The following is a description of a gene set: from publication Gavish A, Tyler M, Greenwald AC, Hoefflin R, Simkin D, Tschernichovsky R, Galili Darnell N, Somech E, Barbolin C, Antman T, Kovarsky D, Barrett T, Gonzalez Castro LN, Halder D, Chanoch-Myers R, Laffy J, Mints M, Wider A, Tal R, Spitzer A, Hara T, Raitses-Gurevich M, Stossel C, Golan T, Tirosh A, Suvà ML, Puram SV, Tirosh I (PMID 37258682) Genes upregulated in subsets of cells of a given type within various tumors studied in species Homo sapiens Human Gene Set: GAVISH_3CA_METAPROGRAM_ENDOTHELIAL_HEV_2 In this study, an extensive analysis was conducted to define meta-programs (MPs) capturing intra-tumor heterogeneity across a spectrum of tumor types. The approach utilized non-negative matrix factorization (NMF) to analyze each cell type separately within individual tumor samples. This involved the analysis of malignant cells, macrophages, fibroblasts, endothelial cells, epithelial cells, T-cells, and B-cells. NMF was executed with varying parameter values (K=4, 5, 6, 7, 8, 9), thereby generating 39 programs for each cell type per sample. Each NMF program was summarized by the top genes based on NMF coefficients.\nRobust MPs were then delineated for each cell type using a set of stringent criteria, including recurrence within the same tumor, similarity to programs in other tumors, and non-redundancy within a tumor. Subsequently, these robust NMF programs were clustered (per cell type) based on Jaccard similarity, leading to the identification of MPs associated with each cell type.\nTo enhance the quality of the MPs, a refinement steps were undertaken, involving the removal of MPs suspected of reflecting low-quality data (with an overrepresentation of ribosomal proteins or mitochondrial-encoded genes), single-study inclusion, or similarity to miss-annotated cell types., and this is the list of marker genes: SELP, NOS3, ADAMTS1, THBD, CALCRL, ADAM15, ITGA6, ADAMTS6, PTGDS, TSHZ2, TGM2, FBLN2, ENTPD1, PLEC, VCAM1, PCDH12, DUSP23 (dual specificity phosphatase 23), SEMA3F, HEG1, APOL1, SELE, HYAL2, TNXB, MALL, PGM5, RAMP3, PRCP, VCAN, MARCKS, EPHB4, NDRG1, EMP3, PCDH17 (protocadherin 17), STC1, TEK, SPTAN1, PLAC9, SLC6A6, CRIP1, VEGFC, FN1, NR2F2, ACKR1, KLF2, APLNR, ADIRF, SLCO2A1, IGFBP5, EHBP1L1, VWF